The following is a description of a gene set: Mouse Gene Set: MP_INCREASED_MEDULLOBLASTOMA_INCIDENCE Mouse genes annotated to increased medulloblastoma incidence (MP:0006283) retrieved from the Mouse Genome Informatics database via MouseMine from publication Motenko H, Neuhauser SB, O'Keefe M, Richardson JE (PMID 26092688) species: Mus musculus, and this is the list of marker genes: Lig4, Trp53, Smo, Trim37, Ifng, Cxcr6, Ptch1